The following is a description of a gene set: species: Homo sapiens from publication Chen Y, Wang X (PMID 31504780) Genes predicted to be targets of miRBase v22 microRNA hsa-miR-4647, hsa-miR-4662b in miRDB v6.0 with MirTarget v4 prediction scores > 80 (high confidence targets). Human Gene Set: MIR4647_MIR4662B, and this is the list of marker genes: PRR27 (NCBI Gene Id 401137), LRFN5, ENPEP, KBTBD8, RNF38, GSK3B, ARL8B, VPS4A, RNF170, SELENOV, SH3BP2, TMOD2 (tropomodulin 2), PLCB1, CD24 (CD24 molecule), MTCL1, GABBR1, KCNG3, FAM168B, TRPC5, WDFY3, SLC16A1, MYORG, RASA1, ZDHHC15, PCID2, PIGW, UBR2, RPS23, GPR180, DEFB132 (defensin beta 132), STAU2, RIPOR2, KNCN, C2CD5, GALK2, NONO, FAR1, DCBLD2, RELL1, ZMYM3, CACNB4, IHH, UBXN8, EIF4E, LCORL, CCSER2, MMP8, PBX2, PLCH1, KAT6A, PHF14, RAB14, KIF2A, N4BP2L2, RANBP9, ATF7, GRIA4, CNOT9, ABCC10, FBXO33, ACOX1, REV1, HDAC2, ITGAD, USP47, DNAJA2, DISC1, DHFR, MTMR4, PDCD10, GAREM1, GTF2A1, COL1A2, SLC9B2, OPA3, ZFP64, FBXW8, TOB1, ARID1B, SSBP2, ANGEL2, SCYL2, EFHC2, TSLP, ZNF655, PTPRT, SOX6, SLC22A2